Given this list of marker genes Itpr1, Irf2, Smim14, Ebf1, H3f3a, Ifi203, Hexb, Itm2b, Serpinb1a, Shisa5, Ypel3, Apoe, Mndal (myeloid nuclear differentiation antigen like), Bmyc, Crip1, Gng2, Fcmr, Arhgap45, Cd52, Cd81, Sh3bgrl3, Cst3, Lbh, Mef2c, Itga4, Pou2f2 (NCBI Gene Id 18987), Pecam1, Siglecg, Septin6, Cybb, Fcrla, S100a10, Fosb, Ptpn18, Jun, Ltb, Filip1l, Trim34a, Iglc3, Gmfg, Ptprc, Btg1, Mbnl1, Macf1, Cd72, Fau, Gimap1, Bach2, Ccr7, Srgn, Rasgrp2, Cmah, Gnai2, St8sia4, Cox7a2l, Rnase6, Cxcr4, Neurl3, Myl12b, Lsp1, Celf2, Gimap6, Evl, Fth1, Marchf1, Cd79a, Laptm5, Tmsb10, Pfdn5, here is a description of the gene set: Cytokines mediate cell-cell communication in the immune system and represent important therapeutic targets. A myriad of studies have highlighted their central role in immune function, yet we lack a global view of the cellular responses of each immune cell type to each cytokine. To address this gap, the authors created the Immune Dictionary, a compendium of single-cell transcriptomic profiles of more than 17 immune cell types in response to each of 86 cytokines (>1,400 cytokine-cell type combinations) in mouse lymph nodes in vivo. A cytokine-centric view of the dictionary revealed that most cytokines induce highly cell-type-specific responses. For example, the inflammatory cytokine interleukin-1β induces distinct gene programmes in almost every cell type. A cell-type-centric view of the dictionary identified more than 66 cytokine-driven cellular polarization states across immune cell types, including previously uncharacterized states such as an interleukin-18-induced polyfunctional natural killer cell state. Genes negatively differentially expressed in cell type: B cell upon treatment with cytokine: IL-4 in mouse lymph nodes in vivo. Mouse Gene Set: CUI_B_CELL_IL4_RESPONSE_DN studied in species Mus musculus from publication Cui A, Huang T, Li S, Ma A, Pérez JL, Sander C, Keskin DB, Wu CJ, Fraenkel E, Hacohen N (PMID 38057668)